Given this list of marker genes CNTNAP1, AKT1, CDK5, CITED2, ASCL1, PSPN, SOD1, PARD3, HAND2, GSTM3 (glutathione S-transferase mu 3), EDNRB, LAMA2, SCN8A, MYOC, RAF1, SKI (NCBI Gene Id 6497), NGF, PMP22, NEUROG3, ADGRG6, NHLH2, MAP2K2, RUNX3, HAPLN2, ETV1, POU4F1, NCMAP, MAPK1, GPC1, DICER1, PALS1, COL6A1, NDRG1, PLEC, RUNX1, EGR3, ADGRB1, PPP3R1, CDK1 (cyclin dependent kinase 1), ONECUT2, HOXD9, TBCE, NTRK3, ERBB3, SOS1, ALDH3A2, LGI4 (NCBI Gene Id 163175), HOXD10, MAP2K1, GDNF, MED12, SLC25A46, ISL2, ADGRB2, SIRT2, NAB1, NTRK2, POU3F2, DAG1, FA2H, HRAS, NFASC, MAPK3, SOX10, SOX8, ARTN, GRB2, SH3TC2, POU3F1, NF1, NRG1, NEFH, SERPINI1, VCAM1, ISL1, RELA, ILK, GFRA3 (NCBI Gene Id 2676), ARHGEF10, ERBB2, UGT8, NAB2, ITGB4, PRX, EGR2, AKT2, CLDN1, PLXNA4, LAMB2, here is a description of the gene set: Human Gene Set: GOBP_PERIPHERAL_NERVOUS_SYSTEM_DEVELOPMENT The process whose specific outcome is the progression of the peripheral nervous system over time, from its formation to the mature structure. The peripheral nervous system is one of the two major divisions of the nervous system. Nerves in the PNS connect the central nervous system (CNS) with sensory organs, other organs, muscles, blood vessels and glands. studied in species Homo sapiens